Given this list of marker genes Nfkbib, Ikbkb (NCBI Gene Id 16150), Psmd13, Rela, Uba52, Psmb7, Psmc1, Skp1, Potefam3d, Rps27a, Nfkb1, Psmb1, Psma5, Psma4, Psma1, Psmd8, Potefam3c, Psmd1, Psmc6, Prkcb, Psmd3, Psmd7, Ubb, Psmd6, Psmb6, Psma2, Psma3, Psmd14, Bcl10, Uba52rt, Psmd12, Cul1, Psma7, Psmc2, Psmc4, Psmb3, Psmb2 (NCBI Gene Id 27983), Card11, Psmc3, Fbxw11, Psmd2, Nfkbia, Psmb4, Psmc5, Ikbkg, Ubc, Psmb5, Chuk, Rel, Adrm1, Malt1, Psma6, Psmd11, here is a description of the gene set: Activation of NF-kappaB in B cells studied in species Mus musculus Mouse Gene Set: REACTOME_ACTIVATION_OF_NF_KAPPAB_IN_B_CELLS